Given this list of marker genes Thoc5, Nck1, Dusp6, Pxt1, Kcna2, Pcnx3, Camsap2, Arhgap31, Lrp2bp, Star, Mtor, Rasl12 (RAS-like, family 12), Chodl, Gm2026, Lrrc4 (NCBI Gene Id 192198), Limk2, Bace1, Lmo2, Sned1, Kif26a, Tmem255a, Ndrg1, Cyp27a1, Nabp1, Wscd2 (NCBI Gene Id 320916), Slc35f1, Pon1, Fbxl2, Gm4724, Lrrc39, Rinl, Sh3pxd2a, Sertm1, Gm14308, Lrif1, Tmem139, Colec11, Nudt4, Hoxa4, Pkig, Lmx1a, Tanc2, Cd19, Gm14434 (predicted gene 14434), Ktn1, here is a description of the gene set: Genes predicted to be targets of miRBase v22 microRNA mmu_miR_6996_3p in miRDB v6.0 with MirTarget v4 prediction scores > 80 (high confidence targets). Mouse Gene Set: MIR_6996_3P studied in species Mus musculus from publication Chen Y, Wang X (PMID 31504780)